The following is a description of a gene set: from publication Querec TD, Akondy RS, Lee EK, Cao W, Nakaya HI, Teuwen D, Pirani A, Gernert K, Deng J, Marzolf B, Kennedy K, Wu H, Bennouna S, Oluoch H, Miller J, Vencio RZ, Mulligan M, Aderem A, Ahmed R, Pulendran B (PMID 19029902) Genes down-regulated in comparison of unstimulated peripheral blood mononuclear cells (PBMC) versus PBMC 21 days after stimulation with YF17D vaccine. The immune responses generated by YF-17D by profiling genes in 25 vaccine recipients were accessed at days 1, 3, 7, and 21 post-vaccination compared to pre-vaccination in PBMCs. The immune responses generated by YF-17D by profiling genes in 25 vaccine recipients were accessed at days 1, 3, 7, and 21 post-vaccination compared to pre-vaccination in PBMCs. species: Homo sapiens Human Gene Set: GSE13485_CTRL_VS_DAY21_YF17D_VACCINE_PBMC_DN, and this is the list of marker genes: LINC02209, VBP1, FBXL19-AS1, PRSS59P, GRM5, METTL27, RPF2, REG1B, TRAC, PNPLA5, ADAD1, CNTNAP1, LINC00052, CCNYL7, GAB4, TMEM106C, KRTAP9-8 (keratin associated protein 9-8), ANKRD22, DAP3, MOBP, NUDT16-DT, PCDHAC2, ABCA4, MIP, CDSN, CCL11, PRR23E, KIF9-AS1 (KIF9 antisense RNA 1), INTS4P1, CUZD1, ST7-AS2 (NCBI Gene Id 93654), DMAC1, SV2C, SLC34A3, C17orf100, CFAP70, PUS7L, ITGA10, REDIC1, PNPLA4, GRIK3, LRRC52, CHRM1, LINC02523 (long intergenic non-protein coding RNA 2523, NCBI Gene Id 649627), CHRND, KCNJ11, TMEM98, MAP3K15, DIRC1 (NCBI Gene Id 89749), CHRNA3, KCNJ5-AS1, PPP2R3A, LINC00339, ANKUB1, C5orf46, SLC17A1, LRRN2, CCL20, METTL5, CLIP3, ASMT, PCDHGA3, MAT1A, CCHCR1, CLDN19, NXPE4, SLC5A4, PIRT, ZACN, PRIM1, HOTTIP, PTPRB, ZNF491, NYNRIN, GRPR, GALNT14, EFCAB5, HTR1D, ZKSCAN3, AIFM2, PRR36, CXCL12, IRAG1-AS1, FAM78B, PPP1R2C, THOC6, GJA5, ELOA3P, ENSG00000261070, SYT2, HIF3A, C6orf163 (NCBI Gene Id 206412), FBXO16, ENSG00000281732, SHMT1, RANBP17, DYNLT2, ZNF175, LINC00626 (long intergenic non-protein coding RNA 626), CYP3A7, UCP1, PMS2P11, EDRF1-DT, GABRA3, ILVBL, FBXL18, KCNK17, POU2AF3, ACADS, CPN2, PAX9, CELA3A, AHI1-DT, C20orf203, FSHR, CNTNAP4, GTF2H5, STT3A, VN1R4, ISX, GPRC5D-AS1, LINC00589, OPTC, BPIFA4P, IL6-AS1, ZNF747, SMIM30, DDC-AS1, LINC02577, MAP3K9, ASXL3, LIN9, A4GNT (alpha-1,4-N-acetylglucosaminyltransferase), CFAP157, ZIM2, LDHAL6A, NLGN3, TMEM79, CDYL2, SYT13, MCM3, RSPH14, SEC61G, ERH, WDR87, PRDM16, CFAP74, SRCIN1, LINC00656, GPR137, PRRX1, SMTNL2, ST8SIA3, GRIA4, DEFT1P, FGF6, MCHR2 (NCBI Gene Id 84539), C12orf60, TTTY7, HCCAT5, ACP5, LGALS14, EPOR, H4C1, LRRTM1, HSPB6, NLRP14, LINC00642, VN1R1, APOH, PLA1A, ZNF135, KSR2, CDT1, OR52A1, PTH2, PLA2G10, PGBD5, NR2E1, TBCA, MNX1, PTGIS, PPARG, NSG2, RPL3L